The following is a description of a gene set: Genes up-regulated by TP53 and down-regulated by an isoform of TP63 in primary HEK cells (epidermal keratinocytes). Human Gene Set: SCHAVOLT_TARGETS_OF_TP53_AND_TP63 from publication Schavolt KL, Pietenpol JA (PMID 17404570) species: Homo sapiens The mechanism by which the p53 family of proteins coordinately regulates select target genes after various types of cell stress is not well understood. To further define factors that dictate regulation of target genes, we examined the binding of p53, DeltaNp63alpha and RNA polymerase II (pol II) to the regulatory regions of select target genes in primary human epidermal keratinocytes (HEKs) using chromatin immunoprecipitation. In rapidly proliferating cells, we observed constitutive binding of DeltaNp63alpha and varying levels of p53 binding, to consensus sites in target genes involved in cell cycle arrest, DNA repair and apoptosis. Following genotoxic stress, p53 occupancy increased whereas DeltaNp63alpha occupancy decreased at the majority of binding sites examined. Microarray analysis of transcripts isolated from HEKs ectopically expressing p53 and DeltaNp63alpha revealed an inverse regulation of select target genes by the two family members. Collectively, our results suggest that DeltaNp63alpha can function as a repressor of select p53 target genes involved in growth arrest, DNA repair and apoptosis, and that the location of the p53 consensus binding site(s) in a target gene may dictate whether pol II is constitutively bound in proliferating cells., and this is the list of marker genes: PCNA, EPHA2 (NCBI Gene Id 1969), CASP1, FAS, PMAIP1, TP53I3, MDM2, VCAN, CDKN1A, FDXR, SFN (NCBI Gene Id 2810), PODXL, PIDD1, BAX, RRM2B (NCBI Gene Id 50484)